Given this list of marker genes MIR101-1, MIR520C, MIR17 (microRNA 17), ITM2A, MIR147A, ITM2C, MIR644A, MIR455, ABCA7, MIR323A, MIR20A, AATF, MIR153-1 (NCBI Gene Id 406944), BACE2 (NCBI Gene Id 25825), MIR106A, MIR144, MIR31, MIR298, ITM2B, AGO2, here is a description of the gene set: Any process that stops, prevents, or reduces the frequency, rate or extent of the chemical reactions and pathways resulting in the formation of amyloid precursor protein (APP), the precursor of amyloid-beta. species: Homo sapiens Human Gene Set: GOBP_NEGATIVE_REGULATION_OF_AMYLOID_PRECURSOR_PROTEIN_BIOSYNTHETIC_PROCESS